The following is a description of a gene set: species: Mus musculus A collagen trimer that forms networks. Mouse Gene Set: GOCC_NETWORK_FORMING_COLLAGEN_TRIMER, and this is the list of marker genes: Col4a1, Col4a6 (collagen, type IV, alpha 6), Col4a5, Col10a1 (collagen, type X, alpha 1), Col4a2, Col4a3, Col4a4